Given this list of marker genes CRELD1, RAF1, PTPN11, TBX1, KRAS, SOS1, TBX5, TBX20, NKX2-5, GATA4, here is a description of the gene set: Genes for which mutations result in developmental defects in ventricular septation and atrioventricular cushion formation, a major class of congenital heart disease. Human Gene Set: BRUNEAU_SEPTATION_VENTRICULAR species: Homo sapiens from publication Bruneau BG (PMID 18288184) Congenital heart disease is the leading cause of infant morbidity in the Western world, but only in the past ten years has its aetiology been understood. Recent studies have uncovered the genetic basis for some common forms of the disease and provide new insight into how the heart develops and how dysregulation of heart development leads to disease.